The following is a description of a gene set: species: Mus musculus A mitotic cell cycle process comprising the steps by which the nucleus of a eukaryotic cell divides; the process involves condensation of chromosomal DNA into a highly compacted form. Canonically, mitosis produces two daughter nuclei whose chromosome complement is identical to that of the mother cell. Mouse Gene Set: GOBP_MITOTIC_NUCLEAR_DIVISION, and this is the list of marker genes: Apc, Chmp4b, Usp44, Mki67, Igf2, Fgfr3, Mir124a-3, Rcc1, Cdca2, Ncapg, Prpf4b, Zfp207, Hnrnpu, Pibf1 (NCBI Gene Id 75821), Vps4b, Dctn2, Reep3, Rgcc, Ncapd2, Chmp7, Map10, Reep4, Ankle2, Becn1, Anapc7, Nuf2, Fgf8, Clasp1, Nsfl1c, Cenpc1, Mad2l1bp, Ndel1, Ofd1, Hspa1b, Ccdc61 (NCBI Gene Id 232933), Nfib, Chmp2a, Cdc16, Edn1, Anapc5, Ino80, Chmp3, Obsl1 (NCBI Gene Id 98733), Fbxo43, Dis3l2, Mis12, Ccsap, Plk1, Npm2, Klhdc8b, Met, Cenpi, Nipbl, Tom1l1, Fbxw5, Tex14, Smc2, Pdgfrb, Kif23, Arhgap33os, Chmp6, Neurog1, Aaas, Chmp1b2, Uhrf1, Mir124a-2, Ube2c, Nup62, Birc5, Smpd3, Lcmt1, Il1a, Phb2, Nudc, Pdgfb, Ska2, Nsl1, Baz1b, Brox, Cdca5, Akap8l, Cdca8, Pebp1 (phosphatidylethanolamine binding protein 1), Il1b, Kntc1, Cd28, Abraxas2, Ncaph2, Champ1, Cenpk, Kif18a, Cdkn1c, Cep85, Nme6, Smarca5, Ska3, Ereg, Bub3, Kpnb1, Ncapg2, Tpr, Cenpe, Sirt1, Kat2b, Anapc15, Egf, Cdkn1b, Sphk1, Ncapd3, Usp16, L3mbtl1 (NCBI Gene Id 241764), Nfia, Kif18b, Numa1, Ccnb1-ps, Chek1, Mybl2, Cep97, Anapc15-ps, Rad21, Atf6b, Prickle1, Banf1, Lsm14a (NCBI Gene Id 67070), Khdc3, Cdk11b, Vps4a, Poldip2, Kif4, Ubxn2b, Pcid2, Cul3, Gen1, Espl1, Cdc20 (NCBI Gene Id 98038), Ppp2r1a (NCBI Gene Id 76182), Cdc14b, Fgfr2, Atm, Wapl, Mad1l1, Btc, Zw10, Dusp1, Tubg1, Chmp2b, Cul9, Smc4, Prc1, Trip13, Stag1, Prap1, Kif14, Spc25, Ndc80, Kif2a, Stag2, Kif3b, Ankrd53, Spc24, Cdk5rap2, Mapre1, Spast, Flna, Spag5, Cul7, Knstrn, Smc1a, Ccdc8, Cep192, Kif22, Ranbp1, Aurka, Ik, Abraxas1, Chek2 (checkpoint kinase 2), Igf1r, Psmg2, Zwint, Ywhah, Cltc, Ppp2r2d, Akap8, Golga2, Incenp, Pdxp, Phf13, Nusap1, Epgn, Misp, Tpx2 (NCBI Gene Id 72119), Cdc23, Tgfa, Chmp5, Spice1, Ube2srt, Kifc1, Arhgef10, Eml4, Lrp5, Cdt1, Cdc42, Snhg15, Chmp1a, Dmrt1, Cav2, Dync1li1, Nfix, Mad2l1, Fbxo5 (NCBI Gene Id 97658), Chmp1b, Xrcc3, Tubg2, Cit, Bub1b, Ska1, Sh2b1, Ttk, Drg1, Ripor2, Kifc5b, Kat5, Psrc1, Ccnb1 (cyclin B1), Nek2, Edn3, Drd3, Esr1, Nfe2l1, Ncaph, Rangrf, Tgfb1, Rab11a, Kif2c, Pinx1, Rb1, Wrap73, Tnf, Clasp2, Ube2s, Haspin, Tom1l2, Eml3, Mir124a-1, Spdl1, Phip, Katnb1, Rpl24, Bccip, Ins2, Anapc11, Hoxa13, Ctdp1, Rhoa, Hspa1a, Insr, Map9, Knl1, Nsmce2, Racgap1, Ran, Cdk1, Igf1, Rrs1, Cdc14a, Kif11, Zwilch, Mtbp, Mzt1, Ccdc66, Smc3, Seh1l, Aurkb, Bmp7, Chmp4c, Bora, Eps8, Nde1, Kif15 (kinesin family member 15), Ins1, Klhl22 (NCBI Gene Id 72509), Bub1, Bmp4